The following is a description of a gene set: Changes in mouse liver mRNA profiles following intraperitoneal cytokine injection. Either interferon-gamma-/-, albumin-cre(-) Socs3(w/fl) mice, or albumin-cre(+) Socs3(-/fl) mice were injected with either phosphate-buffered saline, interferon-gamma, or interfeukin-6, and livers taken after 4h. Genes down-regulated in liver: untreated versus IL6 injection. Human Gene Set: GSE369_PRE_VS_POST_IL6_INJECTION_IFNG_WT_LIVER_DN species: Homo sapiens from publication Croker BA, Krebs DL, Zhang JG, Wormald S, Willson TA, Stanley EG, Robb L, Greenhalgh CJ, Förster I, Clausen BE, Nicola NA, Metcalf D, Hilton DJ, Roberts AW, Alexander WS (PMID 12754505), and this is the list of marker genes: PAK2, KIF27, ADD3, HDAC5 (NCBI Gene Id 23342), MTURN, MAF, LASP1, CRAT, METTL14, INTS4, BDP1, TAS1R1, PUM2, DIPK2A, SFR1, LRCH1, DPYSL2, NRM, SMCHD1, PRKCD (NCBI Gene Id 5580), AGO2, ZMYM2, COL6A5, ANKRD44, CLCF1 (NCBI Gene Id 23529), MDC1, NF1, SSBP2, UBALD2, CHD2, LRRC42, PML, ARPC5, RFK, SPICE1, YWHAH, LFNG (NCBI Gene Id 3955), C16orf54, PAFAH1B3 (NCBI Gene Id 5050), MYADM, PPM1J, TAGAP, SFXN3, TAGLN2, PIK3CD, DMPK, RHOF, SCML4, FAM32A, PRDM4, LMO2, CSNK1G3, IL4I1, CSTF2T, PIKFYVE, TCP11L2, CDK2AP2, CIITA, SF3A3, BCDIN3D, ELP5, HDAC10, DYNLT3, RNF2, DGKA, COLCA1, CMTM7, GUCD1, IPO13, SLCO5A1, GPS2, SNX2, MYO1C, ACBD3, BTLA (B and T lymphocyte associated), DUSP3, MBL2, F2RL1, XRN2, RASGRP2, BRI3, B3GNT5, MED11, MXI1, ABCA1, SFN, ZFP36L2 (NCBI Gene Id 96706), ITGA6, RBM38, XPO6 (NCBI Gene Id 23214), HEATR5A, ROM1, RAP1B, KLF3, GATA5, B4GALNT1, PPM1A (NCBI Gene Id 5494), ORAI2, QPRT, GPR146, BCL6, EMP3, VAT1, SLAMF1, SIKE1, GRB7, MIF4GD, IL4R, LLGL1, ZNF830, BRPF3, DNAJC9, FCMR, KCTD14, FAM117B, CDC25B, HSD11B1, TAF5, PRSS12, CAPN1, FRAT1, AFF4, CXXC1, TBC1D14, CPM, MFGE8, CISD3, MARVELD2, IER2, SSH2, CREBRF, C1orf198, MYO9A, RALGDS, SH3BP5, PRKX, SLC25A2, PRDX5, MAZ, LRRC23, IFIT1, PCIF1, MAML1, DMWD, CDC42SE1, RAP1A, JAK1, SH3PXD2A, SNX9, NEK7, PTK2B, AIP, MTSS1 (NCBI Gene Id 9788), PRKD2, HVCN1, PTPRO, GPN2, VPREB3, RNF144A, RAPGEF4, APC, FCHSD2 (NCBI Gene Id 9873), MAP1LC3A, TAOK1, ASTL (NCBI Gene Id 431705), S100A10, DAXX, EHD4, TESK1, MTAP, GPSM3, TPR, ARL4C, GBE1, RRAD, GPR155, DUSP2, CKAP4, HNRNPUL2, MYO1G, DGKD, PTPRCAP, ARHGEF3, HEXB, DDC, CARD6, PDE2A, STARD8, AP1M1, AHNAK, MADD, ENPP1, TXNDC5, RFC1, MAGOH, CDK19, FLNA, PIK3CG, KIF21B, FAM221A